Given this list of marker genes RAB3B, SLC22A3, SNCA, DRD1, SLC29A4, SLC18A1, ACTB, DRD2, PRKN, GDNF, MAPK15, SLC6A3, DRD4, TOR1A, DRD3, SLC22A1, PARK7, SLC6A2, SLC22A2 (NCBI Gene Id 6582), here is a description of the gene set: Human Gene Set: GOBP_CATECHOLAMINE_UPTAKE studied in species Homo sapiens The directed movement of catecholamine into a cell.